The following is a description of a gene set: studied in species Mus musculus Mouse Gene Set: GOMF_MHC_CLASS_I_PROTEIN_COMPLEX_BINDING Binding to a class I major histocompatibility complex., and this is the list of marker genes: Tapbpl, Klrc1, Cd8a, Klrc2, Tapbp, Klrd1, Cd160 (CD160 antigen)